The following is a description of a gene set: A dynein complex found in eukaryotic cilia and flagella; the motor domain heads interact with adjacent microtubules to generate a sliding force which is converted to a bending motion. studied in species Mus musculus Mouse Gene Set: GOCC_AXONEMAL_DYNEIN_COMPLEX, and this is the list of marker genes: Dnah7a, Dnah17, Dnai4, Dnhd1, Dnah2, Dnai7, Ccdc65, Drc1, Dync1i2 (dynein cytoplasmic 1 intermediate chain 2), Dnah6 (NCBI Gene Id 669400), Dnah12, Dnah7c, Dnah1, Dnah10, Dnah8, Dnah3, Dnah9, Dnal1, Dnai1 (NCBI Gene Id 68922), Dnai3, Odad1, Dnah7b, Dnah5, Cfap70, Nme8 (NCBI Gene Id 73412), Dnai2, Ccdc103